Given this list of marker genes ADNP, SERPINB1, ARID1B, IVNS1ABP, MPI, FERMT2, DYNC1I1, H2AX, MFHAS1, MEIS2, PRF1, EDARADD, LYVE1, TCF7L2, PEF1, PTPN9, SYT1, TRIM71, NR3C1, ARPP19, RBFOX1, ZC3H12B, TCHH, PRDM16, ENHO, DTD2, UROC1, UBFD1, TNR, LRRTM3, BARHL1, LRTOMT, BLTP3A, EIF2AK2, PLOD2, CHP2, RSBN1L, TESK2, DDB2, PSMB9, LGR4, PGM2, here is a description of the gene set: species: Homo sapiens Human Gene Set: MIR328_3P from publication Chen Y, Wang X (PMID 31504780) Genes predicted to be targets of miRBase v22 microRNA hsa-miR-328-3p in miRDB v6.0 with MirTarget v4 prediction scores > 80 (high confidence targets).